Given this list of marker genes TNFSF10, OAS3, LGALS9, PPM1K, BST2 (bone marrow stromal cell antigen 2), SAMD9L, SAT1, HELZ2, IFI44L, GBP1, LY6E, RSAD2, MX1, XAF1, UBE2L6, CD38, ISG20, MX2, IFIT1, PLSCR1, IFIT3, LAP3, EIF2AK2, OAS2, IRF7, IFIH1, SAMD9, HERC5 (HECT and RLD domain containing E3 ubiquitin protein ligase 5), NT5C3A, MT2A, NMI, IFI16, ISG15, ZBP1, IFIT2, CMPK2, IFI6, PARP9, PARP14, SP110, STAT1, IFI44, TYMP, TRIM22, USP18, OASL, IFI35, OAS1, EPSTI1, RIGI, here is a description of the gene set: studied in species Homo sapiens Genes upregulated in subsets of cells of a given type within various tumors In this study, an extensive analysis was conducted to define meta-programs (MPs) capturing intra-tumor heterogeneity across a spectrum of tumor types. The approach utilized non-negative matrix factorization (NMF) to analyze each cell type separately within individual tumor samples. This involved the analysis of malignant cells, macrophages, fibroblasts, endothelial cells, epithelial cells, T-cells, and B-cells. NMF was executed with varying parameter values (K=4, 5, 6, 7, 8, 9), thereby generating 39 programs for each cell type per sample. Each NMF program was summarized by the top genes based on NMF coefficients.\nRobust MPs were then delineated for each cell type using a set of stringent criteria, including recurrence within the same tumor, similarity to programs in other tumors, and non-redundancy within a tumor. Subsequently, these robust NMF programs were clustered (per cell type) based on Jaccard similarity, leading to the identification of MPs associated with each cell type.\nTo enhance the quality of the MPs, a refinement steps were undertaken, involving the removal of MPs suspected of reflecting low-quality data (with an overrepresentation of ribosomal proteins or mitochondrial-encoded genes), single-study inclusion, or similarity to miss-annotated cell types. from publication Gavish A, Tyler M, Greenwald AC, Hoefflin R, Simkin D, Tschernichovsky R, Galili Darnell N, Somech E, Barbolin C, Antman T, Kovarsky D, Barrett T, Gonzalez Castro LN, Halder D, Chanoch-Myers R, Laffy J, Mints M, Wider A, Tal R, Spitzer A, Hara T, Raitses-Gurevich M, Stossel C, Golan T, Tirosh A, Suvà ML, Puram SV, Tirosh I (PMID 37258682) Human Gene Set: GAVISH_3CA_METAPROGRAM_CD8_T_CELLS_INTERFERON